Given this list of marker genes Pitpnc1, Osbpl2, Pitpnm1, Tnfaip8l3, Scp2, Pitpnb, C2cd2l, Pitpna, Pitpnm2, Pltp (NCBI Gene Id 18830), here is a description of the gene set: Removes phosphatidylinositol from a membrane or a monolayer lipid particle, transports it through the aqueous phase while protected in a hydrophobic pocket, and brings it to an acceptor membrane or lipid particle. studied in species Mus musculus Mouse Gene Set: GOMF_PHOSPHATIDYLINOSITOL_TRANSFER_ACTIVITY